The following is a description of a gene set: species: Homo sapiens Frontotemporal dementia Human Gene Set: HP_FRONTOTEMPORAL_DEMENTIA A dementia associated with degeneration of the frontotemporal lobe and clinically associated with personality and behavioral changes such as disinhibition, apathy, and lack of insight. The hallmark feature of frontotemporal dementia is the presentation with focal syndromes such as progressive language dysfunction, or aphasia, or behavioral changes characteristic of frontal lobe disorders., and this is the list of marker genes: ANG, CCNF, TUBA4A, PON1, SORL1, DAO (D-amino acid oxidase), PON2, TOMM40, TMEM106B, C9orf72, TBK1, GLT8D1, GLE1, CHMP2B, OPTN, UBQLN2, FUS, GRN, NEK1, ATXN2, VCP, TREM2, PRPH, FIG4 (NCBI Gene Id 9896), MATR3, ZFYVE26, PSEN1, DCTN1, TAF15, CFAP410, ANXA11, ERBB4, UNC13A, TIA1, NEFH, PRKAR1B, ABCA7, CYLD, HNRNPA2B1, TARDBP, PSEN2, PON3, SOD1, HNRNPA1, APP (NCBI Gene Id 351), MAPT, PLA2G6, CHCHD10, VAPB, SQSTM1, PFN1, PPARGC1A